The following is a description of a gene set: Genes up-regulated in blood samples from bladder cancer patients. studied in species Homo sapiens PURPOSE: Recent data indicate that cDNA microarray gene expression profile of blood cells can reflect disease states and thus have diagnostic value. We tested the hypothesis that blood cell gene expression can differentiate between bladder cancer and other genitourinary cancers as well as between bladder cancer and healthy controls. EXPERIMENTAL DESIGN: We used Affymetrix U133 Plus 2.0 GeneChip (Affymetrix, Santa Clara, CA) to profile circulating blood total RNA from 35 patients diagnosed with one of three types of genitourinary cancer and compared their cDNA profiles with those of 10 healthy subjects. We then verified the expression levels of selected genes from the Affymetrix results in a larger number of bladder cancer patients (n = 40) and healthy controls (n = 27). RESULTS: Blood gene expression profiles distinguished bladder cancer patients from healthy controls and from testicular and renal cancer patients. Differential expression of a combined set of seven gene transcripts (insulin-like growth factor-binding protein 7, sorting nexin 16, chondroitin sulfate proteoglycan 6, and cathepsin D, chromodomain helicase DNA-binding protein 2, nell-like 2, and tumor necrosis factor receptor superfamily member 7) was able to discriminate bladder cancer from control samples with a sensitivity of 83% (95% confidence interval, 67-93%) and a specificity of 93% (95% confidence interval, 76-99%). CONCLUSION: We have shown that the gene expression profile of circulating blood cells can distinguish bladder cancer from other types of genitourinary cancer and healthy controls and can be used to identify novel blood markers for bladder cancer. from publication Osman I, Bajorin DF, Sun TT, Zhong H, Douglas D, Scattergood J, Zheng R, Han M, Marshall KW, Liew CC (PMID 16740760) Human Gene Set: OSMAN_BLADDER_CANCER_UP, and this is the list of marker genes: INTS6, APOBEC3C, MS4A7, KPNA6, C3AR1, VTA1, NKTR, SMC3, TMEM107, AASDH, MAP3K2, CD44, RAB14, NEAT1, KLF2, MS4A3, CCSER2, PARP4, RSBN1, DCUN1D1, UBQLN2, UBXN4, WDR41, GCLM, MTDH, FXR1, EWSR1, PHC3, TWF1, PNISR, RAD21, ERGIC1, SDHC (succinate dehydrogenase complex subunit C), SRP72, TNFSF13, PSENEN, RING1, MAGT1, SYNCRIP, HSPA13, LNPK, UBXN7, NNT, CENPU, BRWD3, ACBD5, STK4, PABPN1, RUNX3, HAVCR2, UHMK1, TNPO1, FYB1 (FYN binding protein 1), BICD2, A2M-AS1, PTPN22, SEC24A, HSP90B1, USP16, AKAP13, RAB27A, STRN3, TNRC6B, INO80D, SLC25A13 (solute carrier family 25 member 13), SECISBP2, KLHL24, ALDH2, FLNA, SLC26A2, ERGIC2, RHOQ, BCLAF1, TAPBP, TBC1D8, HAUS6, PRF1, SNRNP48, IER3IP1, CAMKK2, MARCHF1, PTCD3, CCND3, NKG7, ADSS2, CYP1B1, IRAK3, SERINC3, RBM12B, ACTR3, MS4A4A, DHX36, APPL1, PIAS1, BLM, KMT2C, KPNA3, DESI2, LACTB2, SSX2IP, NDUFS1, FGFR1OP2, XRCC4, WASHC4, ESF1, TTC17, MACROH2A1, CITED2, BAX, SDF4, CCZ1, NBN, C19orf12, TMED8, KYNU, AGTRAP, KCTD12, CHST2, PLSCR1, NRIP1, TNKS2, ZFYVE16, MAP3K20, B4GALT6, ARPC4, G2E3, SNX13, SARNP, PRR11, EMB, LDLRAD3, PTGER2, TMEM33, LYPLA1, SNHG5, RFXANK, RAB10, MAN2A1, ATP6V1D, LIN7C, UGCG, ALG13, ZYG11B, NXT2, SF3B1, TMOD3, NFE2L2 (NFE2 like bZIP transcription factor 2), FRMD4B, ZMAT3 (zinc finger matrin-type 3), SAE1, CBX6, LILRA2, YY1, OXR1, TMED5, FAR1, EIF2S1 (NCBI Gene Id 1965, eukaryotic translation initiation factor 2 subunit alpha), SLC25A40, TMEM106B, ASPHD2, YEATS4, LPGAT1, TGFB1, FPGT, PTPRC, IQGAP1, ZDHHC5, CTSC, NMD3, MOB1A, GLUD1, RPS6KC1, DCAF10, CDADC1 (cytidine and dCMP deaminase domain containing 1), DNAJB14, MFF, ZFAND3, AGO3, SOCS2, SLC1A4, RIOK3, ATP11B, MALAT1, SAMHD1 (NCBI Gene Id 25939), UBA6, SUGT1, DIAPH2, RIF1, SPIN4, EIF5, TAF15, CHD9, GANAB, KHDRBS1, CDC5L (cell division cycle 5 like), COQ2, TPP1, PDIA3, OTUD6B, RMDN1, SPI1, CHURC1, SERBP1, SMAD5, ARB2A, AGPS, MR1, CEBPA, THUMPD3, ANKRD17, KTN1, FNIP1, EIF4G1, LNPEP, IRF2BP2, USP42, RNPC3, KLHDC3, PHACTR2, ASB8, NEMF, TGOLN2, TSNAX, TMPO (NCBI Gene Id 7112), SMG1, MED19, HCFC2, KLHL6, CCDC88C, LRRC57, SGMS2, ZNF562, ZNF641, SNX16, GZMH, SCAF11, CRTAP, PHAX, SCP2, EOLA1, UBE2W, ALDH3B1, HSP90AA1 (NCBI Gene Id 89272), RAP2A, RAD23B, MIR3939, SCARB2, PCNA, PLA2G4A, INPP5A, TALAM1, SRP19, IL15, FBXO9, USP47, BSG, RO60, FOXN2, EDEM3, IMPACT, RBMS1, SLC44A1, ZC3H7A, MRPS10, LYST, PRNP, TCF7L2, PIK3R1, STRN, SLC25A37, FBXO22, LILRB1, ZER1, BBX, SCAMP1, DHFR (NCBI Gene Id 203373), ELF1, BLTP1, CERT1 (ceramide transporter 1), RNH1, GAS7, TRAK2, MAPK14, BRD7, PCMTD1, SLC16A6, YWHAE, FBXW5, NCKAP1L, ARIH1, PKM, GNB1, CD48, CRIPT, KBTBD6, ERAP1, SAP30, KLHL7, FCRL2, LDHA, USP1, GRK3, TM9SF4, KPNB1, HCG18, SUZ12, NOL9, TUBB4B, DSTNP2, ENPP4, RECQL, TPM4, SRSF11, ABCB10, RSF1, RNU6-1016P, KLHL9, CALR, TYMS, SNTB2, C1orf162, LGALS3 (NCBI Gene Id 81625), PSME4, MBD4, DYNLL2, SCAMP2, NBPF14, YLPM1, HNRNPL, ZNF253, ZNF316, ATG5 (autophagy related 5), CEP57, AZI2, CTSB, TNPO3, ABRAXAS2, NUDT3, ACTR1A, P4HB, PDAP1, CSNK1A1, DPYD, TIPRL, CD47 (CD47 molecule), JAZF1, TOP1, PTP4A2, FAM107B, SOS1, VASP, THAP6, NFKBIZ, ZNF319, SESTD1, ABHD17A, MEX3C, CCDC125, NUCKS1, ENO1, FAM133B, CPNE3, CTSD, RIPK2, LONRF3, GLYR1, DLEU2, PRPF40A, ACER3, SSH1, TMED7, ITGB2, ZNF148, FAM120A (family with sequence similarity 120 member A), EIF5A, IGFBP7, CYBB, RASA2, TM2D1, WASH9P, GOLIM4, TSPAN31, MCTP2, H1-10, ATF7IP, IFNAR2, PDLIM5, HIPK2, PREP, TMX1, TTC33, SMAD7, GALNT1, MBNL1, SPPL2A, ATXN1 (NCBI Gene Id 7912), GBE1, FCER1G, NAMPT, TBL1XR1, BLOC1S6, SLC25A36, LAIR1